The following is a description of a gene set: from publication Chen Y, Wang X (PMID 31504780) studied in species Homo sapiens Genes predicted to be targets of miRBase v22 microRNA hsa-miR-2681-3p in miRDB v6.0 with MirTarget v4 prediction scores > 80 (high confidence targets). Human Gene Set: MIR2681_3P, and this is the list of marker genes: MRTFB, COL13A1, SGK3, F8A1, EPM2A, SULF1, BAG1, SPRED3, FSCN1, KLK7, TMEM41B, SLC30A1, IL2RA, CEP135, WDR47, SERPINB10, RTN4IP1, PEG3, FAM43A, LRATD1, CD244, NDUFAF6, SEH1L, UNC80, CYP4F3, C8orf44-SGK3, MAP7D2, NAMPT, ARHGAP44, C1orf43, RASGEF1A, TCFL5 (transcription factor like 5), NEFM, RAPGEF3, COA5, STYX, PPM1L